The following is a description of a gene set: studied in species Mus musculus The series of molecular signals initiated by the binding of a ligand (such as a bacterial peptidoglycan) to a cytoplasmic nucleotide-binding oligomerization domain containing 2 (NOD2) protein receptor, and ending with regulation of a downstream cellular process. Mouse Gene Set: GOBP_NUCLEOTIDE_BINDING_OLIGOMERIZATION_DOMAIN_CONTAINING_2_SIGNALING_PATHWAY, and this is the list of marker genes: Hspa1b, Ptpn22, Lacc1 (NCBI Gene Id 210808), Irgm1, Nod2, Nagk, Peli3, Erbin, Nfkbia, Xiap, Slc15a4, Slc15a3, Tnfaip3, Igtp, Inava, Rela, Ripk2, Znrf4, Irgm2, Tlr4, Otulin